The following is a description of a gene set: studied in species Mus musculus Mouse Gene Set: GOMF_EUKARYOTIC_INITIATION_FACTOR_4E_BINDING Binding to eukaryotic initiation factor 4E, a polypeptide factor involved in the initiation of ribosome-mediated translation., and this is the list of marker genes: Eif4ebp1, Rbx1, Eif4ebp3, Ddx3x, D1Pas1, Larp1, Hhex, Angel1, Eif4g1, Eif4ebp2